The following is a description of a gene set: Catalysis of the reactions: protein serine phosphate + H2O = protein serine + phosphate; and protein threonine phosphate + H2O = protein threonine + phosphate. These reactions require the presence of calcium ions. species: Mus musculus Mouse Gene Set: GOMF_CALCIUM_DEPENDENT_PROTEIN_SERINE_THREONINE_PHOSPHATASE_ACTIVITY, and this is the list of marker genes: Ppm1e, Dusp29, Dusp22, Dusp19, Ppm1n, Ppm1f, Rpap2, Ptpmt1, Ppp5c, Pgam5, Cpped1, Ssh1, Cdkn3, Ctdp1, Ppm1b, Dusp3, Dusp23, Pten, Ublcp1, Ctdsp2, Ppp3cc, Ilkap, Ssh2, Dusp2, Ppp3ca, Ppef1, Ppef2, Phlpp2, Dusp6, Ppp4c, Pptc7, Dusp1, Epm2a, Dusp18, Ppp3cb, Ppp1cc, Ppp2cb, Dusp4, Rcan1, Ppm1h, Dusp15, Ppm1k, Ppp6c, Ctdsp1, Dusp21, Ppm1g, Rcan3, Dusp7 (NCBI Gene Id 235584), Cdc14b (CDC14 cell division cycle 14B), Dusp26, Dusp28, Ppm1j, Ssu72, Ppp1ca, Dusp10, Ppp3r1, Rcan2, Ppm1d, Dusp14, Ppm1m, Dusp13a, Ppm1a, Ssh3, Ppm1l, Ppp1cb, Dusp12, Phlpp1, Ppp2ca, Cdc14a, Ppp2r3d, Dusp8 (NCBI Gene Id 71434), Dusp13b, Ppp3r2, Pdxp, Ctdspl, Eya1, Ctdnep1